Given this list of marker genes Grb14, Shb, Gsk3b, Tbx6, Mir133b, Ednrb, Wee2, Dleu2, Npr2, Spinkl, Nppc, Bcl11a, Nox1, here is a description of the gene set: Mouse Gene Set: GOBP_NEGATIVE_REGULATION_OF_CELL_MATURATION studied in species Mus musculus Any process that stops, prevents or reduces the frequency, rate or extent of cell maturation.